The following is a description of a gene set: Human Gene Set: BREDEMEYER_RAG_SIGNALING_VIA_ATM_NOT_VIA_NFKB_UP Genes up-regulated in pre B lymphocyte after induction of physiological DNA double-strand breaks (DSB) by RAG2; the changes depend on ATM but not NFKB signaling. from publication Bredemeyer AL, Helmink BA, Innes CL, Calderon B, McGinnis LM, Mahowald GK, Gapud EJ, Walker LM, Collins JB, Weaver BK, Mandik-Nayak L, Schreiber RD, Allen PM, May MJ, Paules RS, Bassing CH, Sleckman BP (PMID 18849970) species: Mus musculus DNA double-strand breaks are generated by genotoxic agents and by cellular endonucleases as intermediates of several important physiological processes. The cellular response to genotoxic DNA breaks includes the activation of transcriptional programs known primarily to regulate cell-cycle checkpoints and cell survival. DNA double-strand breaks are generated in all developing lymphocytes during the assembly of antigen receptor genes, a process that is essential for normal lymphocyte development. Here we show that in murine lymphocytes these physiological DNA breaks activate a broad transcriptional program. This program transcends the canonical DNA double-strand break response and includes many genes that regulate diverse cellular processes important for lymphocyte development. Moreover, the expression of several of these genes is regulated similarly in response to genotoxic DNA damage. Thus, physiological DNA double-strand breaks provide cues that can regulate cell-type-specific processes not directly involved in maintaining the integrity of the genome, and genotoxic DNA breaks could disrupt normal cellular functions by corrupting these processes., and this is the list of marker genes: CRIM1, JUN, LTB, SNRNP25, PKD2, IFT81, KIF16B (NCBI Gene Id 79757), ZNF182, DOCK7, DIPK1A, MSRB2, SIVA1, FGGY, CIB1, KIF17, SELL, GOLM1, SLC20A1, CYP2J2, CSRP2, ACER3, KCNK6, PRRG4 (NCBI Gene Id 79056), NFIX, TRIM68, CYBB, ZNF579, TMEM71, NEURL3, ANXA4, RAB39A, QSOX1, TCAIM (T cell activation inhibitor, mitochondrial), THBD, AKR1E2, DUSP16, SH2D5, CLDN34, SMO, IFTAP, LDLRAD3, MAP3K8, IL6ST, BCL11A, COLEC12, NAT1, CAMK2B, PEPD, HOOK1, IGF2BP3, CSGALNACT1, RETREG1